The following is a description of a gene set: studied in species Homo sapiens Human Gene Set: REACTOME_REGULATION_OF_HOMOTYPIC_CELL_CELL_ADHESION Regulation of Homotypic Cell-Cell Adhesion, and this is the list of marker genes: CDH24, BHLHE22, AMOT, HOXC8, ADAM33 (NCBI Gene Id 80382), ADAM19, CTNND1, CTNNB1, TNRC6C, CDH19 (cadherin 19), ZC3H12A (zinc finger CCCH-type containing 12A), ZEB2, TNRC6B (trinucleotide repeat containing adaptor 6B), AGO4, AGO3, TNRC6A, CDH8, AGO1, AGO2, CDH11, FOXF1, PRDM8, JUP, MOV10, MIR200C, ANGPTL4, SNAI1, SP1, HEYL, SOX10, CTNNA1, ILF3